Given this list of marker genes Rbbp9, Fgf10, Nkx2-1, Foxp1, Spdef, Aimp2, Foxp4, Igf1, Ascl1, Gata6, Agr2, Hoxa5 (NCBI Gene Id 15402), Nfib, Fndc3b, here is a description of the gene set: studied in species Mus musculus The process in which a relatively unspecialized cell acquires specialized features of a lung secretory cell. A lung secretory cell is a specialized epithelial cell of the lung that contains large secretory granules in its apical part. Mouse Gene Set: GOBP_LUNG_SECRETORY_CELL_DIFFERENTIATION